The following is a description of a gene set: species: Mus musculus Mouse Gene Set: GOCC_CLATHRIN_SCULPTED_VESICLE A clathrin-sculpted lipid bilayer membrane-enclosed vesicle after clathrin release., and this is the list of marker genes: Syp, Otof, Dnajc5 (DnaJ heat shock protein family (Hsp40) member C5), Vamp2, Slc17a8, Rab3a, Gad2, Gad1, Syn1